Given this list of marker genes OAZ3, FSCN3, CATSPER3, CATSPER1, UBQLN3, CST8, CST9L, KLHL10, ATP6V1E2, ODF1, SPATA3, TNP1, MS4A5, SPACA4, CCIN, here is a description of the gene set: Human Gene Set: WEBER_METHYLATED_LCP_IN_SPERM_UP To gain insight into the function of DNA methylation at cis-regulatory regions and its impact on gene expression, we measured methylation, RNA polymerase occupancy and histone modifications at 16,000 promoters in primary human somatic and germline cells. We find CpG-poor promoters hypermethylated in somatic cells, which does not preclude their activity. This methylation is present in male gametes and results in evolutionary loss of CpG dinucleotides, as measured by divergence between humans and primates. In contrast, strong CpG island promoters are mostly unmethylated, even when inactive. Weak CpG island promoters are distinct, as they are preferential targets for de novo methylation in somatic cells. Notably, most germline-specific genes are methylated in somatic cells, suggesting additional functional selection. These results show that promoter sequence and gene function are major predictors of promoter methylation states. Moreover, we observe that inactive unmethylated CpG island promoters show elevated levels of dimethylation of Lys4 of histone H3, suggesting that this chromatin mark may protect DNA from methylation. Methylated germline-specific genes with low-CpG-density promoters (LCP) in sperm. from publication Weber M, Hellmann I, Stadler MB, Ramos L, Pääbo S, Rebhan M, Schübeler D (PMID 17334365) studied in species Homo sapiens